The following is a description of a gene set: Human Gene Set: WP_NRP1TRIGGERED_SIGNALING_IN_PANCREATIC_CANCER NRP1-triggered signaling in pancreatic cancer studied in species Homo sapiens, and this is the list of marker genes: TGFBR1, TGFBR2, PLXNA2, NRP1, EGFR, MAPK3, RELA, SEMA3A, COL1A1, SNAI2, CCN2, CDH5, RELB, GSK3A, HGF, SRC, REL, TGFB2, MIR141, SMAD2, AKT3, EGF, SLC39A4, MAP2K2, CCNE1, MAP2K1, TGFB3, BCAR1, CDKN1B, TGFBR3, VEGFA, CHD1, CHD2, SMAD4, CDK2, MAPK1, RAC1, MET (NCBI Gene Id 4233), KDR, COL1A2, NFKB2, PLXNA1, AKT2, NFKB1, SNAI1, AKT1, MMP2, SMAD3, FLT1, CCNE2, PTK2 (protein tyrosine kinase 2), PLXNA4, PECAM1, MMP9